The following is a description of a gene set: studied in species Homo sapiens from publication Jeffrey KL, Brummer T, Rolph MS, Liu SM, Callejas NA, Grumont RJ, Gillieron C, Mackay F, Grey S, Camps M, Rommel C, Gerondakis SD, Mackay CR (PMID 16474395) Genes up-regulated in comparison of macrophages versus Th2 cells. Human Gene Set: GSE3982_MAC_VS_TH2_UP In the present study we used Affymetrix oligonucleotide microarrays to produce gene transcription profiles for the major leukocyte types in humans. This comprehensive dataset enabled us to not only establish which genes were expressed in each leukocyte type, but also which genes were expressed in each subset after activation. The used of a comprehensive dataset of gene profiles from all the major human leukocyte subsets enabled a novel and powerful means for identification of genes associated with single leukocyte subsets, or different immune paradigms., and this is the list of marker genes: TSC1, ENPP4, CRYL1, BCL11A, CHRM5, TRDMT1, UBTD1, USP12, VCL, LIN7C, SERTAD3 (SERTA domain containing 3), DNAAF11, ARHGAP22, ANPEP, EGR2, HADHB, ABCC3, HBP1, FIG4, CLOCK, PIK3CB, SST, SPATA2L, CD74, ANKMY1, ANOS1, NRIP3, ALDH3A2, FRMD4A, CDKN1A, FUCA1, PPM1B, GMFB, SWAP70, SLC47A1, MAN2B1, PIK3IP1, MAP1LC3B, ATM, CHN2, PRKAG2, RASAL2, FHIT, BCL10, CSPG4, S100A10, SCG5, GNPDA1, ANXA2P1, KIF16B, CCSER2, LGALS8, GTF2IRD1, STXBP3, PTK2, MMD, INAVA, CCZ1, SNX13, PDHX, SOS2, ANGEL1 (angel homolog 1), HP, TMED7, P2RY2, SKAP2, HS2ST1, HRH4, SOCS5, NAGLU, VAV3 (vav guanine nucleotide exchange factor 3), AP5M1, RAB9A, FBXO38, RAB5IF, WFDC1, LAPTM4A, CEACAM3, HSD17B11, PPP2CB, CTSH, AMIGO2, TMEM140, LAMTOR3, DPPA4, CLIC2, MVB12B, PLXNA1, SPAG9, AKR1C3, RAC1, CAPZA2, ACACB (acetyl-CoA carboxylase beta), TRIO, ENOSF1, LILRA2, SPRY2, ACP2, ZCCHC14, UBE2D1, CEP70, DNAH17, REPS2, DOCK3, EPHX1, HS3ST2, MORF4L1, MAPK1, FRAT1, IFIT3, GCNT2, TSPAN4, LYZL6, C3, GPR137B, SLC11A2, FNDC3B, ACO1, MID2, UCHL1, MARCHF7, SLC11A1, FMO6P, PRCP, PMP22, STAB1, CLN8, CYTL1, DPEP2, FMO5, NRBF2, RNASE4, ZZEF1, UBQLN2, CCL22, DNAJB9, HCAR3, CCRL2, PLEK2, TIMP3, PROC, HK2, FCN1, FXR2, MYO6, UBXN2B, STEAP1, PPFIA1, CHFR, TREM1, RPS6KC1, ZKSCAN3, SMNDC1, CLCN7, DMXL1, YIPF1, RAB36, CPVL, STARD8, TMEM59, KDM7A, CD84, NDRG2, GATM, AZI2, NTAN1, RHOBTB2, GOLGB1, TNPO1, KLHL24, HLA-DRB1, CDK5, TRAF3IP2, SLC7A7, MX2, TBC1D5, DNASE2B, FABP4, ATP6AP2, FZD5, ACOX2, SDC3, GALC, PAPSS1 (NCBI Gene Id 9061), ITPR2, ETV5, ENG, VPS37C, TLX2, CAST, RALGAPA1, IGFBP7, MOSPD1, PLEKHF2, RENBP, INHBA, DCAF6, SLC25A24, PSEN1